The following is a description of a gene set: Genes predicted to be targets of miRBase v22 microRNA mmu_miR_1199_5p in miRDB v6.0 with MirTarget v4 prediction scores > 80 (high confidence targets). from publication Chen Y, Wang X (PMID 31504780) Mouse Gene Set: MIR_1199_5P species: Mus musculus, and this is the list of marker genes: Hapln1, Klhl30, Pnpo, Ccdc69, Gnat1, Taf8, Szrd1 (SUZ RNA binding domain containing 1), H2-T3, Trhr, Usp42, Ninl, Cox15, Pcnx4, Mlec, Wasf1, Slfn5, Wtap, Aadacl3, Stk10, Slc7a11, Mdm1, Ufd1, Sstr3, Zfp566, Cs, Dapp1, Car3, Slc31a1, Slc9b2, Zbtb17 (zinc finger and BTB domain containing 17), Ccdc97, Lrrc8e, Pik3r3, Dynlt3, Zfp366, Zfp24 (zinc finger protein 24), Tlk2, Sall2, Prr15, Iars2, Uchl5, Slc27a4, Adam19, Jph1, Pla2g4e, Ralb, Lrrcc1, Fndc3b, Garem1, Zfp28, Fbxo11 (F-box protein 11), Stk4, Map3k1, Sp1, Sh3kbp1, Spag6l, Cdk17, Elk3, Zdhhc1, Pdpk1, Zeb1, Meioc, Zic5, Lifr, Slc30a5, Kcnk6, Npy1r, Pex11g (NCBI Gene Id 73655), Zbtb44, Il17a, Rgs1, Mfsd8, H2-Ab1, Adcy5, Trim26, Slc9a7, Prpf39, Oga